Given this list of marker genes MIR133A1, MIR26A2, MEF2B, MIR181B1, MIR16-2, MIR302E, TLX1, TLX2, MIR1-1, MIR3591, MYOD1, MIR145 (microRNA 145), MIR181C, MIR133A2, BORCS8-MEF2B, SRF, MIR302A, MIR206, MIR128-1, MIR16-1, MIR150, MIR133B, MIR181A2, LEFTY1, MIR214, MEF2D, MIR155, MIR181A1, MIR17, STAT3, MIR181D, MEF2A (NCBI Gene Id 4205), MEF2C, MIR222, MIR199A2, MIR181B2, MIR146B, TLX3, MIR302D, MIR203A, MIR26A1, MIR9-1, HDAC5, MIR302C, MIR221, MIR3074 (microRNA 3074), MIR223, MIR199A1, MIR20A, LEFTY2, here is a description of the gene set: Cell differentiation - index species: Homo sapiens Human Gene Set: WP_CELL_DIFFERENTIATION_INDEX